Given this list of marker genes SLC26A11, THNSL2, CPLANE1, DAB1, ENSG00000230737, MIR3663 (microRNA 3663), ENAH, GUSBP2, WDR90, ZSWIM6, SURF4, MT-ND6, IL23A, EFHB, ENSG00000249713, SMAD3-DT, FUNDC2, RUNX1, CHST8, HOXA-AS3, CAND1, SYDE2, KCNJ5, MARCKS, GFER, NINL, THADA, ZSCAN31, HOXC8, EHBP1-AS1, IGHVIII-38-1, NECTIN1, BMP1, SOX2-OT, LINC01214, WIF1, TNRC6A, SLC25A12, RNU1-129P, TRPS1, TRIM59, SEMA3A, FHAD1, CTBP2, LINC02987, MAML2, HOXB3, MIR124-1HG, SLTM, NALF1, EBF1, BRINP3-DT, DPP9, KLHDC9, C1orf21, PEX13, PAN2, CFAP418, YAP1, KMT2C, PGAP1, GDF11, APH1A, ZIC5, NFIC, RPL38, IQSEC1, HIVEP3, SIL1, CACNA1G, IGF2BP2, HOXB8 (NCBI Gene Id 3218), FOSL2, RFX3-DT, PIP4K2A, UGT3A2, DPYSL2, SYN3, TEX38, MYH11, KANSL1-AS1, DCAF8-DT, SPRED2, NR2F1-AS1, SLC35B1, SETD5, SOX8, RHOXF1P1, FGFBP3, GPRC5D-AS1, FAM241A, EPM2A-DT, SALL1, PDE4B, ACTN2, CACNG2-DT, HMGA2, HOXC6, PDGFB, GNAS, TBC1D5, TRIM59-IFT80, BRWD1, TIMP3, AP3S2, ASPHD1, PRKCE, ZBTB20, TMX4, PCID2, NUB1, LMF1, RFTN2, ISG20L2P2, DUSP5, SLC7A2, PABPC5, DNAJC6-AS1, INTS5, RCBTB2, NFKB1, RYR3, DUSP16, FOXF2, RHOH, CYP4A22-AS1, AMIGO2, EDIL3-DT, ZNF217, RNU6-563P, SLC35A1, ERBB3, TRPM4, BAZ2B, MAPK10, FGF7, ARHGAP29-AS1, ATF3, ENSG00000247416, COQ5, SET, LBX1-AS1, BLTP3B, PAN3-AS1, C1orf21-DT, CA14, JMJD1C, HOXB6, RAB10, TAFA2, PUS10, PPP4R2, C11orf68, KIF18B, BCL6, CSNK1G3, RGS20, IRX5, P4HA2-AS1, BRWD3, PDZD7, MIR4428, AEBP2, RSAD1, BRF2, GOLM2, GFRA1, FANCC, LY6S-AS1, TMEM132B, CTNND1, TPM4, UBAP2L, HAR1A, REPIN1, CPLX2 (complexin 2), POLG (DNA polymerase gamma, catalytic subunit), MECOM, NFIA, RNU6ATAC34P (NCBI Gene Id 106479557), ZNF793, TSC22D4, RNU1-6P, TRIM16L, ZZEF1, ZFHX4-AS1, ANXA2, SYNE2 (NCBI Gene Id 26075), MEF2C, POLR2K, BASP1-AS1, TFAP2A, TBX3, AUTS2, DBH-AS1, CXXC4, ALX4, MCC, MYLK, CCT8, STING1, REV3L, CBX8, POU3F2, GBX1, RNU1-154P, FLI1 (NCBI Gene Id 2313), TRDMT1, BCL7A, GLI3, GFRA2, NCAM1, MED15P9, RPL27AP, NOSIP, CACNG2, KDM2A, LRBA, HOXD4, LINC02614, LINC02846, TTC4, LINC01409, HMHB1, THSD4, LINC01778, MDGA1, MBIP (MAP3K12 binding inhibitory protein 1), NF1, TACC1, SLITRK3, SNORD3A, G0S2, PCNX2, FRMD5, JADE2, MIR4733, PAN3, ARRDC3-AS1, ZNF793-AS1, ZBTB20-AS4, STRN3, SATB1-AS1, ADAMTS3, ANTKMT, CTSK, PMAIP1, RNU4-2, MARK1, FABP5P3, IL12A-AS1, TMEM170B, RHOXF1P2, ENSG00000257184, ZNF385A, BCL11A, MAP3K8, NPLOC4, ARPC5, MED12L, NDUFA6, TMEM219, C19orf12, BCL9, CARF, VPS51, FRYL, SMARCD2, NDP, GRAMD1B, CEP170P1, MT-TE, CRK, BMP7, LGALS1, GBA1, DZIP1L, ANAPC7, PRDM6-AS1, ARRDC3, ZC3H4, PLEKHG3, KCNK1, LHFPL2, HOXB2, IL1R2, CAMK4 (NCBI Gene Id 814), GGT1, RND2, GABRA2, CD72, ATRN, ZNF462, ZNF775, LINC01022, DBNDD2, KANSL1, TRAPPC3L, SOS1, MTND6P4, RAVER2, DDI2, RPL36P18, MTCYBP18, PGRMC1, HNRNPUL1, RBM25, BTN2A1, TP53TG5, WWTR1-AS1 (WWTR1 antisense RNA 1), SCAF4, LINC01719 (NCBI Gene Id 101928979), LINC01132, VIM, MARCHF6, LINC00662, ATOSA, INPP4B, NOXO1, PNMA2, ATXN1, NPR1, COL14A1, KCNIP4, BBX, FBXW7 (F-box and WD repeat domain containing 7), AMD1, MST1P2, IZUMO2, MAN2C1, ACTR6, MACF1, LINC02832, PROX1-AS1, CENPNP1, LINC00602, ENSG00000249236, CYP2A7, MAFB, ZNF503, SEMA6A, ENSG00000293341, EPOR, NFIX, C1orf43, LAMA4, CT62, FAM168A, PNLIPRP1, PTCH1, SLC25A29, SSBP3P1, PCDH7 (NCBI Gene Id 90855), FOXS1, BTF3P9, FRA10AC1, DUS1L, NDUFS7, CYB5D2, SP3, CREM, CELF4, TMEM255B, ZNF827, MIR221, YBX3, SOX5 (NCBI Gene Id 6660), PITPNC1, SMAD7, MT-TT, SAMD14, RRN3, CT66, KDM3A, MLLT3, SATB1, ZNF74, MIR4453HG, PAXBP1, TCF4, EPCIP-AS1, ZNF703, NCOA7, TGFB3, HSPB9, CCKBR, FGF13, CES3 (NCBI Gene Id 79984), NAV3, PHF21A, WDR62, CORO1C, CFAP276, ERICH1 (glutamate rich 1), SH2D2A, RBM39, DYM, RNU6-1189P, SERBP1P3, SLC35F3, KCNB2, NR2F1, PITPNM3 (NCBI Gene Id 83394), ZMIZ1-AS1, MIR3188, ANO8 (anoctamin 8), SMIM8, CDH22, RPL7AP58, SERPINH1, MEIS2, MALT1, SCN2B, MIR9-2HG, FAM107B, MTF2, NR2F2, PXMP2, LINC02225, TNR, ATG3, TPRA1, ATP2B1, GAD1, PBX2, NSFL1C, LINC03057, PIK3R1, PDZD2, SLC35A5, GATA3, PTMS, EPC1-AS1, MAB21L2, MIR500A, RNU5F-1, TBX18, PCDH9, CEACAM19, MTCO3P12, ZMYM3, HIGD1B, ZFHX3, PDZK1P1, NPAS3, SHOX2, CCT6B, POU6F2, C3orf80, PLXND1, SLC4A5, MTND5P11, HOXB-AS1, USP7, CFDP1, HOXD11, NSG2, DNAJC19P1, EFCAB7, TRIB1, SLC39A13, ECE2, MDM4, PATJ, TRABD2B, ATPAF1, CREB5, EPHB1, TCF7L2, TTC23, JUND, TRH, SEPTIN7, LINC00853, NDUFA6-DT, ETV6, LMOD1, CXADR, NUP107-DT, DRAP1, ZNF710, PPIL2, LINC00960, NREP, WTIP, SVIL, CNTNAP1, SKOR1, MTUS1, HOXB5, ZCCHC2, SLC44A1, STAT3, RAD52, DOCK11, SEMA3C, ACTB, LINC00244, MIR7-3HG, STPG1, SAMD1, GTPBP2, NUP107, SYT2, LINC00240, PAPOLA, GMFB, HOXA10, TMEM200C, GRIA3, NRN1, KLK10, NFIB, DHRS4-AS1, ENSG00000253593, LETM2, RFLNA, SLC4A7, ELMOD1, KCTD15, LYN, ZFHX4, CASTOR3P, AMOTL1, CPVL, FAM171B, PROX1, ENSG00000282375, DLGAP2, TRAF3IP2-AS1, SLC35F2, CDYL-AS1, RNVU1-6, NAA25, MIR8083, MATR3, LINC00114, FBXO30, PRSS12, PCBD2, HMGA1, ELAC1, IPO4, GAPDHP14, POU2F2, RNF38, GTF2H4, KRT14, KMT5B, ATXN1-AS1, VARS2, TRPC5, CCDC159, RNA5SP505, TRIM16 (NCBI Gene Id 10626), FAT3, EP300, KAT2A, RYR3-DT, PDE10A, EVX2 (even-skipped homeobox 2), SNORD118, TRAV21, GPNMB, TMEM101, CELF2, FOXL1, CACNA1A, CDYL, RNF217, IGF2BP3, RNU6-921P, PARP12, CASP7, ARHGEF12, SUMO1, ZFX, ITM2C, SMAD3, PTPA, P3H3, FGFR1, ALG3, PRRX1, SCAMP5, TM9SF4, FAM200A, LINC02086, EEA1 (NCBI Gene Id 8411), MEIS1, CEROX1, LINC02202, CUL4A, MIR320B1 (NCBI Gene Id 100313823), KIAA1671, EPC1, RFX3, PRDM6, TYR, ATP2B4, VWA1, TOB2P1, TRIM25, POLE, CHD2, LINC01798, STX6, ZNF503-AS2, PPP3CC, CCND2, SMAD6, PRMT8, STKLD1, ITGB3BP, VPS25, SPIN4-AS1, CCR10, SLC19A2, PITX2, MIR3200, KLLN, WDR12, CHD8, TMX4-AS1 (TMX4 antisense RNA 1), RNA5S17, BASP1, CBFA2T2 (CBFA2/RUNX1 partner transcriptional co-repressor 2), NUCB1, SIPA1L1, TNRC6B, SEPTIN7-DT, SUZ12P1, ATAD3C, GTPBP3, NECTIN1-DT, BEND3, GAP43, MIR615, LDB1, BRINP3, PLEKHG4 (NCBI Gene Id 6312), MRPL34, RASGEF1A, SIPA1, ACVR1, RBBP7, ARID1A, SNX16, SGK1, ENSG00000222666, MARCHF6-DT, PAFAH1B1, NR3C1, ELAPOR1, RNF43, PTEN, UBE3C, IGFL4, SCN1B, BICD1, SRCAP, EDIL3, ZMIZ1, CROCCP2, SOX2, GLMP, KCNN3, here is a description of the gene set: Human Gene Set: ZNF596_TARGET_GENES species: Homo sapiens Genes containing one or more binding sites for (ZNF596) in their promoter regions (TSS -1000,+100 bp) as identified by GTRD version 20.06 ChIP-seq harmonization. from publication Yevshin I, Sharipov R, Kolmykov S, Kondrakhin Y, Kolpakov F (PMID 30445619)